The following is a description of a gene set: studied in species Homo sapiens Reactome Pathway: Biological oxidations part of: Metabolism All organisms are constantly exposed to foreign chemicals every day. These can be man-made (drugs, industrial chemicals) or natural (alkaloids, toxins from plants and animals). Uptake is usually via ingestion but inhalation and transdermal routes are also common.<p><p>The very nature of many chemicals that make them suitable for uptake by these routes, in other words their lipophilicty (favours fat solubility) is also the main reason organisms have developed mechanisms that convert them to hydrophilic (favours water solubility) compounds which are readily excreted via bile and urine. Otherwise, lipophilic chemicals would accumulate in the body and overwhelm defense mechanisms. This process is called <b><i>biotransformation</i></b> and is catalyzed by enzymes mainly in the liver of higher organisms but a number of other organs have considerable ability to process xenobiotica such as kidneys, gut and lungs. As well as xenobiotics, many endogenous compounds are commonly eliminated by this process.<p><p>This mechanism is of ancient origin and a major factor for its development in animals is plants. Most animals are plant eaters and thus are subject to a huge variety of chemical compounds which plants produce to stop themselves being eaten. This complex set of enzymes have several features which make them ideal for biotransformation;<p><p><i>(<b>1</b>) metabolites of the parent chemical are usually made more water soluble so it favours rapid excretion via bile and urine</i><p><p><i>(<b>2</b>) the enzymes possess broad and overlapping specificity to be able to deal with newly exposed chemicals</i><p><p><i>(<b>3</b>) metabolites of the parent generally don't have adverse biological effects.</i><p><p>In the real world however, all these criteria have exceptions. Many chemicals are transformed into reactive metabolites. In pharmacology, the metabolites of some parent drugs exert the desired pharmacological effect but in the case of polycyclic aromatic hydrocarbons (PAHs), which can undergo epoxidation, it results in the formation of an electrophile which can attack proteins and DNA.<p><p>Metabolism of xenobiotica occurs in several steps called <i><b>Phase 1 (functionalization)</b></i> and <i><b>Phase 2 (conjugation)</b></i>. To improve water solubility, a functional group is added to or exposed on the chemical in one or more steps (Phase 1) to which hydrophilic conjugating species can be added (Phase 2). Functional groups can either be electrophilic (epoxides, carbonyl groups) or nucleophilic (hydroxyls, amino and sulfhydryl groups, carboxylic groups) <i>(see picture)</i>.<p><p>Once chemicals undergo functionalization, the electrophilic or nucleophilic species can be detrimental to biological systems. Electrophiles can react with electron-rich macromolecules such as proteins, DNA and RNA by covalent interaction whilst nucleophiles have the potential to interact with biological receptors. That's why conjugation is so important as it mops up these potentially reactive species.<p><p>Many chemicals, when exposed to certain metabolizing enzymes can induce those enzymes, a process called <i><b>enzyme induction</b></i>. The effect of this is that these chemicals accelerate their own biotransformation and excretion. The reverse is also true where some chemicals cause enzyme inhibition. Some other factors that alter enzyme levels are sex, age and genetic predisposition. Between species, there can be considerable differences in biotransformation ability which is a problem faced by drug researchers interpreting toxicological results to humans., and this is the list of marker genes: CYP21A2, MGST3, CYP1A1 (cytochrome P450 family 1 subfamily A member 1), PTGIS, ADH1A, CYP2U1, AOC3, SULT1A1, MGST2, CYP3A4, TPST1, ACSS1, GLYAT, CYP2F1, CYP4F11, FDXR (ferredoxin reductase), FMO3, CYP26C1, CYP2C8, CYP4F12, GSTM1 (NCBI Gene Id 92085), FMO2, GSTA3, HPGDS (hematopoietic prostaglandin D synthase), CYP19A1, CYP39A1, CHAC2, ACSS2, UGT1A1, GSTA2, CYB5B, HEMK2, GSTM5, CYP8B1, CYP4F8, CYP1B1, GSTO2, AOC2, UGT2B17, ADH1B, CYP4A22, CYP2A6, CYP2C18, CYP24A1, GLYATL1, PODXL2, CYP27B1, ALDH3A1, UGT2A1, CYP2A7 (cytochrome P450 family 2 subfamily A member 7), SLC35D1, AOC1, NNMT, GSTP1, AKR7A3, UGT2B28, SULT1A2, GSTT2B, GLYATL3 (glycine-N-acyltransferase like 3), HSP90AB1, ALDH2, ADH1C, CYP2C9, SULT1B1, BPHL, NAT2, PTGS1, CYP4V2 (cytochrome P450 family 4 subfamily V member 2), CYP7B1, TPMT, AS3MT, ACSM4, SULT1C4, UGT2A2, ACSM2A, GGT5, ARNT, MGST1, GGT3P, CYP2R1, MAT1A, UGT1A4, ACY1, CYP2E1 (NCBI Gene Id 1571), ESD, UGT2B11 (UDP glucuronosyltransferase family 2 member B11), GGT6, CYP2B6, SULT6B1, CYP2C19, CYP3A7 (cytochrome P450 family 3 subfamily A member 7), GCLM, UGT1A10, CYP4F22, UGT1A5, CYP26A1, CYP4A11, SULT4A1, EPHX1, GGT1, AKR1A1, SULT2A1, GSTA1, GSTT2, GSTM2, CYP2S1, CYB5R3, UGP2, CYP11A1, CYP2J2, NAT1, CYP1A2, AHCY, CYP26B1, CMBL, UGT1A8, FDX1, UGT3A2, SULT1E1, SULT1C2 (NCBI Gene Id 6819), ADH7, CYP51A1, CYP2A13, ALDH1A1, CYP4F2, CYP11B1, GGCT, UGT2B15, MTRR, CES2, ABHD14B, UGT1A6, DPEP1, UGT3A1, POR, POMC, GSTM4, CES3, ACSM5, GGT7, RXRA, CYP11B2 (NCBI Gene Id 1585), ACSM2B, GSTK1, MTR, ADH5, AADAC (arylacetamide deacetylase), CBR3, CYP3A43, ACY3, ALDH1B1, MAOB, GSS, CYP46A1, COMT, CYP3A5, UGDH, NCOA1, UGT1A7 (UDP glucuronosyltransferase family 1 member A7), UGT2B7, SULT2B1, GLYATL2, SLC35D2, CYP4B1, MAT2A, ADH4 (alcohol dehydrogenase 4 (class II), pi polypeptide), AHR, ARNT2, ACSM1, UXS1, AKR7L, GSTA5, NQO2, UGT2B10, AIP, OPLAH, CHAC1, GSTO1, ABHD10, BPNT2, TRMT112, FDX2, TPST2, TBXAS1, FMO1, UGT1A3, BPNT1, DPEP2, AHRR, SMOX, CYP27A1, CYP7A1, MAOA, UGT1A9, GSTZ1, AKR7A2, GCLC, CYP4F3, SULT1A3, NR1H4, UGT2A3, MTARC2, CYP2W1, GSTT1, MTARC1, UGT2B4, CYP2D6, ADH6, NCOA2, GSTA4, GSTM3, SULT1A4, MAT2B, PTGES3, PAOX, CES1, CNDP2